The following is a description of a gene set: species: Homo sapiens Human Gene Set: HP_3_4_FINGER_CUTANEOUS_SYNDACTYLY A soft tissue continuity in the A/P axis between fingers 3 and 4. 3-4 finger cutaneous syndactyly, and this is the list of marker genes: EFNB1, GLI3, KCTD1, TP63, PORCN, MAB21L2, H4C9, TBX5, CDH3, KAT6A (NCBI Gene Id 7994), SALL1, CPLANE1, CACNA1C, HOXD13, TMEM53, GJA1, BBS2